Given this list of marker genes LSM3, LSM7, LSM5, LSM1, LSM2 (LSM2 homolog, U6 small nuclear RNA and mRNA degradation associated), here is a description of the gene set: A conserved, heteroheptameric, cytoplasmic protein complex composed of Lsm1, Lsm2, Lsm3, Lsm4, Lsm5, Lsm6, Lsm7, and Pat1, or orthologs thereof, that shows a strong binding preference for oligoadenylated RNAs over polyadenylated RNAs. May bind further associated proteins. Facilitates the deadenylation-dependent decapping of mRNA in the P-body thereby regulating mRNA decay and subsequent degradation by the 5' to 3' pathway. species: Homo sapiens Human Gene Set: GOCC_LSM1_7_PAT1_COMPLEX